The following is a description of a gene set: Human Gene Set: KEGG_MEDICUS_REFERENCE_BMP_HAMP_SIGNALING_PATHWAY Pathway Definition from KEGG: BMP2/6 -> ((ACVR2B,BMPR2)+(ACVR1,BMPR1A) -> (SMAD1,SMAD5,SMAD9) == SMAD4 => HAMP species: Homo sapiens BMP-HAMP signaling pathway. Pathway ID: N01458. Pathway type: Reference. Pathway class: nt06507 TGFB signaling., and this is the list of marker genes: ACVR2B, SMAD9, ACVR1, BMPR2 (NCBI Gene Id 659), HAMP, BMP2, SMAD4, SMAD1, SMAD5, BMP6, BMPR1A